Given this list of marker genes TRNT1, INTS2, PPP2CA (NCBI Gene Id 5515), ZCCHC7, ARMC5, INTS8, PPP2R1A, DIS3, INTS11, EXOSC4, INTS14, EXOSC2 (exosome component 2), INTS7, INTS5, XRN1, INTS9, EXOSC5, EXOSC8 (NCBI Gene Id 11340), INTS15, INTS12, EXOSC6, EXOSC10, PELO, INTS6, INTS3, SUPV3L1, INTS13, INTS1, WDR82 (WD repeat domain 82), EXOSC7, INTS10, DXO, RBX1, EXOSC3, EXOSC9, ZC3H4, INTS4, here is a description of the gene set: studied in species Homo sapiens Human Gene Set: GOBP_RNA_SURVEILLANCE A process that identifies and degrades defective or aberrant RNAs.